The following is a description of a gene set: studied in species Homo sapiens Assembly of gap junctions, which are found in most animal tissues, and serve as direct connections between the cytoplasms of adjacent cells. They provide open channels through the plasma membrane, allowing ions and small molecules (less than approximately a thousand daltons) to diffuse freely between neighboring cells, but preventing the passage of proteins and nucleic acids. Human Gene Set: GOBP_GAP_JUNCTION_ASSEMBLY, and this is the list of marker genes: AGT, GJC1, CNTNAP2, GJB1, GJB2, IL1B, GJA5, GJA1, CTNNA1, IRX3, CAV1, HOPX, GJD3, TBX5, ACE, GJB6, APLNR, ACE2 (NCBI Gene Id 59272)